The following is a description of a gene set: A calcium channel complex in the mitochondrial inner membrane capable of highly-selective calcium channel activity. Its components include the EF-hand-containing proteins mitochondrial calcium uptake 1 (MICU1) and MICU2, the pore-forming subunit mitochondrial calcium uniporter (MCU) and its paralog MCUb, and the MCU regulator EMRE. Mouse Gene Set: GOCC_UNIPLEX_COMPLEX studied in species Mus musculus, and this is the list of marker genes: Mcub, Micu2, Mcu, Micu3, Smdt1, Micu1